The following is a description of a gene set: Human Gene Set: GSE17721_LPS_VS_PAM3CSK4_0.5H_BMDC_DN mouse primary BMDCs were stimulated with tlr ligands and gene expression changes were profiled on Affymetrix arrays from publication Amit I, Garber M, Chevrier N, Leite AP, Donner Y, Eisenhaure T, Guttman M, Grenier JK, Li W, Zuk O, Schubert LA, Birditt B, Shay T, Goren A, Zhang X, Smith Z, Deering R, McDonald RC, Cabili M, Bernstein BE, Rinn JL, Meissner A, Root DE, Hacohen N, Regev A (PMID 19729616) Genes down-regulated in comparison of dendritic cells (DC) stimulated with LPS (TLR4 agonist) at 0.5 h versus DC cells stimulated with Pam3Csk4 (TLR1/2 agonist) at 0.5 h. studied in species Homo sapiens, and this is the list of marker genes: INO80, WFS1, NME6, NIPA2, UHMK1, CTSB, ETV3, NCOA6, TMEM179B, SLC1A5, BCLAF1, CXCL17, IL17RC, GPNMB, MPP1, FGL2, GRB7, HNRNPM, PCDHB5, JMJD1C, EIF6, KRTAP13-2, RABEPK, MYOZ1, RYK, CHURC1, BHLHE41, MTMR14, C16orf74, BAIAP2, CXCL13, PIGQ, IAPP, HTATSF1, NANOG, PEX14, SLC6A4, PPBP, LAMA3, BCL2L2, HS3ST3A1, PDLIM1, HPGDS, HAS3, C6orf62, EIF4G1, SRPK1, PRPF39, KIAA0513, IFT81, KMT5B, SLC19A2, PTGR2, KSR1, SLC47A1, SRGN, CELF1, CTSK, PAX4, ADIG, BRINP1, ALG5, PAK1IP1, LSR, ENG, PDE6H, RPAP1, PWP2, PHF13, AKR1C3, RHO, RNF13, FNDC7, ATF5, HRH3, ACAA1, PYY, IL6ST, GPRASP1, HBG2, TEC, BRWD3, STC1, ATAD2B, LAPTM4A, SAAL1, FGFR1, PRADC1, GPN3, PLEKHA6, FJX1, NIPAL2 (NCBI Gene Id 79815), VIL1, UPF3B, METTL18, ANO1, PRSS35, TRIP12, INPPL1, CX3CR1, NAPB, SLC22A3, PACS1, ORM1, ESCO1, PSMA5, CAPN6, OAS2, PKDREJ, PPP1R18, RNF44, HOXD1, ATP6V1C1, ENPP3, RAG2, KRTAP15-1, MNX1, EN1, SALL2, SAG, RIPK4, UMPS, KRT34 (NCBI Gene Id 3885), LITAF, STRN3, PCDH7, CBX6, SYP, DEPDC1 (DEP domain containing 1), DMC1, KCNJ15, RHBDL3, DLG3 (discs large MAGUK scaffold protein 3), ELK4, CCDC175, RILPL1, PRELID3A, TWIST1, SH3BGRL3, SLC6A2, LRWD1, SS18, PRKD3, CREB3L1, CD52, LIN7B, SLC27A5, TMEM268, RBX1, ADORA2A, G6PC1, PTPRS, TBPL1, CHRDL1, TSPO2, INTS11, RARS1, LTBP3, FTL, CLEC7A, TMEM98 (NCBI Gene Id 26022), SELENOT, THBS3, ERBIN, CBY1, AGL, SNRNP70, SFTPB, LCLAT1, RALGDS, CAVIN3, CDKN2D, MSI1, IL20, GLE1, RBL1, PRSS22, USP17L2, CLEC14A, KIAA2013, PPP6R3, LRATD1, AGAP3, KCNK13, ROCK1, RPS6KA2, EEA1, COL5A2, IL10RA, HOXD13, COPZ2, TAC1, CD44, MRPS28, DHX36, H1-10, FN1, CCL20, HPRT1